Given this list of marker genes S100A14 (S100 calcium binding protein A14), NFKBIZ, UNC93B1, GRAMD4, COLEC10, ZC3HAV1, GPS2, RELA, NLRP6, ANKRD17 (ankyrin repeat domain 17), PLCG2, MEFV, TNF, DHX33, CD14, NAGK, IRF5, FCN3, CTSS, MAPKAPK3, IFI35, RAB7B, ERBIN, RIOK3, SIN3A, LTF, TRIM65, GKN2, TLR1, MIR708, IRAK4, PJA2, HCFC2, CLEC6A, ZDHHC1, TRIM15, RNF144A, RBM14, IFI16, CD300A, HSPD1 (NCBI Gene Id 56733, heat shock protein family D (Hsp60) member 1), AARS2, MYD88, HSPA1A, CHUK, HAVCR2, HSP90AA1, SLC46A2, AIM2, MIR146A, DDX41, PQBP1 (polyglutamine binding protein 1), WASHC4 (WASH complex subunit 4), TRIL, MIR19A, MIR4691, SQSTM1, ZCCHC3 (NCBI Gene Id 85364), LRRC14, NINJ1 (ninjurin 1), KCNJ8, OASL, TRIM31, NFKBIL1, TNIP1, RSAD2, ABHD17A, FCN1, GBP2, MIR200B, APPL2 (adaptor protein, phosphotyrosine interacting with PH domain and leucine zipper 2), RTN4, TASL, TNIP2, TRIM32, ARRB2, STMP1, FYN, LAMP2, BANF1, PUM1, TMEM126A, TLR10, RNF170, PPP6C, ZDHHC12, FCN2, PHB1, NFKBIA, GPR108, CASP6, FFAR2, KLRK1, TOMM70, CARD8, PCBP2, XRCC6, ALPK1, NR1H4, CGAS, RIPK2, FCRL3, SFPQ, PAK1, PYDC5, NLRC4, OGT, CD274, USP50, EIF2AK2, SYK, TKFC, COLEC12, APP, RAB11FIP2, HSPA1B, MATR3, ZNRF4, SPSB3, SCARA3, ITCH, NAGLU, COLEC11, WDFY1, BRCC3, TLR4, IRAK3, TIFA, SLC15A2 (solute carrier family 15 member 2), TRAF3IP3, LILRA4, ZNRF1, TICAM1, TREML4, FOSL1, S100A9, HEXIM1, TLR7, PYHIN1, TYRO3, DDX60, TRAF6, USP17L2, TRIM5, OAS1, NOD1 (nucleotide binding oligomerization domain containing 1), TAB1, CASP1, YWHAE, OTULIN, ZDHHC5, NLRP1, CLPB, MAPKAPK2, PTPRS, CD300LF, ACOD1, SRC, RNF39, LYPLAL1, IRAK2, MFHAS1, NAIP, RPS6KA3, DAB2IP, STING1, LATS1, KLRD1, LATS2, GBP5, GPATCH3, CLEC4E, SMPDL3A, ZBP1, BIRC2, TRAF3, BTK, LSM14A, BCL10 (NCBI Gene Id 8915), TYROBP, UFD1, ABHD8, MAVS, KIR2DS2, PYDC2, PUM2, IRAK1, MNDA, IRF7, MIR200C (NCBI Gene Id 406985), IPO5, EPG5, PARP1, NMI, USP15, IFIH1, TRIM3, ESR1, CYLD, NR1D1, ELP6, UBQLN1, MIR20A, CLEC7A, APPL1, ZDHHC9, IKBKE, MBL2, FLOT2, GDI1, PYCARD, ZDHHC18, MAPK8 (NCBI Gene Id 5599), XIAP, CSNK1A1, NLRP10, PAK2, TLR2, HSP90B1, PPP2CA, TSPAN6, BPIFB1, PSPC1, ZDHHC3, KLRC2, TBK1, TRIM25, LACC1, TREM2, TARBP2, NLRX1, TICAM2, CPTP, AURKB, CACTIN, PELI1, RNF125, LGR4, TNIP3, TNFAIP3, OTUD4, TLR6, DHX58, TAX1BP1, KLRC4-KLRK1, REG3G, KLRC4, SLC15A3, KLRC1, PRKDC, XRCC5, TLR9, BIRC3, CYBA, TIRAP, C1QBP, TRIM11, ECSIT, AKT1, SCIMP, BECN1, PIK3R1, PAK3, MAP3K7, HMGB1, INAVA, FBXL2, NOP53 (NCBI Gene Id 94457), LETMD1, PDPK1, MARK4, NPLOC4, TLR8, HDAC6, P2RX7, S100A8, IRF1, RFTN1, NLRP2B, AP3B1, SLC19A1, SIRT2, NLRC3, KLRC3, TREX1, RNF135, ATAT1, IKBKB, NR1H3, PRKD1, TIFAB, MIR149, PHB2, DDX3X (NCBI Gene Id 730543), IRF4, PYDC1, OAS3, FLOT1, EP300, PIK3AP1, CCDC134, PRKCE, MIR210, HSPA8, MARCHF5, ZNFX1, PPT1, RNF115, LBP, TLR3, CD36, LILRA2, LRCH4, LGALS9, SEC14L1, TLR5, NOD2, SARM1 (NCBI Gene Id 23098), IRF3, IRGM, HCK, RNF34, SMPDL3B, CAV1, KCNK13, PTPN22, MAP2K6, MIR140, LY96, NEK7 (NCBI Gene Id 148565), LRRC19, F2RL1, LYN, GFI1, KCNK6, NONO, RIGI, MIR17, CREBBP, NLRP3, SLC15A4, here is a description of the gene set: species: Homo sapiens Human Gene Set: GOBP_ACTIVATION_OF_INNATE_IMMUNE_RESPONSE Any process that initiates an innate immune response. Innate immune responses are defense responses mediated by germline encoded components that directly recognize components of potential pathogens. Examples of this process include activation of the hypersensitive response of Arabidopsis thaliana and activation of any NOD or TLR signaling pathway in vertebrate species.